Given this list of marker genes ZNF318, RPL36A-HNRNPH2, ZNF516, NFATC2, PDE7B, TMEM59, SGCZ, RNF220, ZNF135, ZFP90, ZNF419 (NCBI Gene Id 79744), PROCR, SOX6, LOXL4, EFNA5, BAZ2B, ZNF594, GPR88, ZNF704, BNC2, TMEM101, ANKRD28, ZNF215, TAPT1, CYCS, IFNA21, ATP11C (NCBI Gene Id 57206), SEPTIN8 (septin 8), PHF21A, ZSCAN22, DNAI4, LHFPL3, SWAP70, PCDHB13, ELAVL4, KPNA4, ZFP1, CLIP1, PABIR3, FCER1G, FEM1C, GGCX (NCBI Gene Id 2677), PASK, DACH1, HSD3B2, ZNF268, PDS5B, SOBP, ARHGAP32, PIPOX, ZFAND5, RAD23B, ZNF589, HDHD5, JOSD1, ADCY1, ZNF195, ZNF75A, CPSF4, ZNF773, SLC25A40, RMND5A, MAFA, GTPBP1, NBEA, JMJD1C, NPPC, SLCO1A2, ZNF711, PCGF5, MTUS2, SMG1, MBOAT2, SLC35F1, DERL2, ZNF584, ZNF512, ZNF780B, EPYC, RDH8, GSE1, PAPPA, USH1C, NTF3, STAT1, here is a description of the gene set: Human Gene Set: MIR7978 species: Homo sapiens from publication Chen Y, Wang X (PMID 31504780) Genes predicted to be targets of miRBase v22 microRNA hsa-miR-7978 in miRDB v6.0 with MirTarget v4 prediction scores > 80 (high confidence targets).